The following is a description of a gene set: species: Homo sapiens Genes predicted to be targets of miRBase v22 microRNA hsa-miR-591 in miRDB v6.0 with MirTarget v4 prediction scores > 80 (high confidence targets). Human Gene Set: MIR591 from publication Chen Y, Wang X (PMID 31504780), and this is the list of marker genes: SPRR2G, GALNT2, PRR14L, BNC2, SPARC, MEX3B, TUBB2A, BCLAF1, DLG1, RBMS3, NRK, MIER3, CLASP1, TRPS1 (transcriptional repressor GATA binding 1), PPP2R5B, CCNL1, KLF4, NEGR1, TMEM178B, CCNJ, ELAPOR2, CBFB, BORCS7, N4BP2L2, PPP3CB, SERBP1, DNAAF6, CNKSR3, ZEB1, PKD2 (polycystin 2, transient receptor potential cation channel), FBRSL1, MPP7, RRAD, AHCYL1, SPAG6, KLHL2, SIN3A, VPS26A, CLPX, CNKSR2, PLCB4, MS4A7, KRT33B, KCNK2, ABCC3, SYNPR, EOLA1, RANBP9, TAOK1, PFKM